Given this list of marker genes SLCO1C1, SLC35C2, SLC2A4, SLC38A1, SLC37A2, SLC6A4, SLC35D2, SLC22A6, SLC10A5, SLC25A1, SLC8A2, SLC6A9, SLC34A2, SLC26A11, SLC25A23, SLC35C1, SLC39A4, SLC17A9, SLC29A1, SLC39A8, SLC10A2, SLC5A10, SLC37A3, SLC25A6, SLC47A2 (solute carrier family 47 member 2), SLC30A8, SLC9A5 (solute carrier family 9 member A5), SLC6A3, MCU, SLC17A8, SLC25A26, SLC18A3, SLC11A2, SLCO4C1, SLC35E2A, SLC22A11, SLC36A2 (NCBI Gene Id 153201), SLC15A5, SLC6A13, SLC37A4, SLC1A3, SLC12A1, SLC30A1, SLC44A4 (solute carrier family 44 member 4), SLC35E1, SLC10A7, SLC16A5, SLC46A2, SLCO4A1, SLC17A1, SLC28A3, MFSD2B, SLC30A10, SLC22A7, SLC26A5, ANKH, ADAMTS8, SLCO1B3, SLC10A4, SLC9A2, SLC6A14, SLC5A6, SLC44A2, SLC23A2, SLC25A12, SLCO1B3-SLCO1B7, SLC2A13, SLC26A10P, CDH17, GHITM, SLC15A4, SLC6A7, SLC35A2, MFSD12, CLCN4 (NCBI Gene Id 4412), SLC35E3, SLC6A18, SLC26A7, SLC7A13, SLC11A1, SLC39A10, SLC36A1, SLC6A17, CLCN7, SLC44A5, SLC15A3 (solute carrier family 15 member 3), SLC6A11 (solute carrier family 6 member 11), SLC12A9, SLC26A3, SLC4A3 (NCBI Gene Id 7858), SLC26A9, SLC38A5, SLCO5A1, SLC35A3, SLC25A4 (NCBI Gene Id 7872), MFSD1, SLCO1A2, SLC16A12, SLC9A9, SLC24A4, SLC16A1, SLC16A4, SLC46A3, SLC22A1, SLC35A5, SLC10A3, SLC10A6, SLCO6A1, SLC13A2, SLC12A5, SLC9A6, SLC25A16, SLC10A1, SLC45A3, SLC44A1, SLC8A1, SLC17A2, SLC6A20, SLC25A25, SLC38A7, SLC16A9, SLC35E4, SLC9A1, SLC30A2, TMEM165, SLC47A1, SLC12A2, SLC24A2, SLC25A31, SLC17A4, SLC9A4, SLC39A14, SLC25A21 (NCBI Gene Id 89874), SLC2A9, SLC30A9, SLC25A11, SLC9C1, SLC5A12, SLC7A9, SLC36A4, SLC25A13, SLC4A1, SLC38A4, SLC5A2, SLC25A18, SLC5A11, SLCO1B1, SLC5A4, SLC16A7, SLC46A1, SLC39A6, SLC12A8, SLC16A2, SLC16A13, SLC1A2, SLC45A4, SLC30A4 (solute carrier family 30 member 4), SLC25A14, SLC8A3, SLC20A2, SLC26A4, SLC24A5, CLCN3, SLCO2B1, SLC28A1, SLC22A18, SLC38A2, SLC20A1, SLC34A3, SLC9B1P1, SLC18B1, SLC13A1, SLC17A5, SLC22A4 (solute carrier family 22 member 4), SLC18A2, SLC7A5, SLC6A16 (solute carrier family 6 member 16), SLC28A2, SLC23A1, SLC6A8, CLCN6, SLC39A5, SLC6A6, UCP2, SLC1A6, SLC6A15, SLC25A10, SLC24A1, SLC1A1, SLC24A3 (NCBI Gene Id 96617), SLC22A9, SLC30A3, SLC4A5, SLC1A5, SLC9A7, SLC26A6, SLC35E2B, SLC17A3, SLC15A1, SLC22A5, SLC30A5, XPR1, SLC41A3, SLC5A1, SLC26A8, SLC45A1, SLC13A4 (NCBI Gene Id 26266), SLC4A10 (NCBI Gene Id 57282), SLC39A12, SLC5A9, SLC35B2, SLC18A1, SLC35A1, SLC9B1, SLC16A11 (NCBI Gene Id 162515), SLC5A3, SLC12A7, SLC16A10, SLC35B1, SLC4A8, SLC5A5, CHP1, SLC25A30, SLC35D3, SLC25A15, MFSD4B, SLC12A4, SLC37A1, MFSD2A, SLC25A2, SLC9A8, SLC1A4, SLC4A7, SLC25A17, SLC19A1, SLC13A5, SLC4A2, SLC6A12, SLC45A2, SLC9A3, SLCO3A1, SLC12A3, SLC25A5, SLC4A4, SLC6A19, SLC30A6, SLC9B2, SLC22A8, SLC6A1, SLC25A24, SLC16A3, SLC6A5 (NCBI Gene Id 9152), SLC32A1, SLC2A10, SLC13A3, SLC7A6, SLC17A6, SLC41A1, SLC35B3, SLC25A20, SLC8B1, SLCO1B7, SLC15A2, LETM1, SLC17A7, SLC4A9, SLC36A3, SLC5A7, SLC38A3, SLC16A14, SLC1A7, SLC16A8 (solute carrier family 16 member 8), SLC26A2, CTNS, SLC4A11, SLC7A8, SLC25A19, TMCO3, SLC34A1 (solute carrier family 34 member 1), SLC25A3, SLCO2A1, SLC35D1 (solute carrier family 35 member D1), SLC5A8, SLC6A2, SLC25A22, SLC7A11, SLC9C2, SLC12A6, SLC26A1, CLCN5, TMEM241 (transmembrane protein 241), here is a description of the gene set: Human Gene Set: GOMF_SECONDARY_ACTIVE_TRANSMEMBRANE_TRANSPORTER_ACTIVITY Enables the transfer of a solute from one side of a membrane to the other, up its concentration gradient. The transporter binds the solute and undergoes a series of conformational changes. Transport works equally well in either direction and is driven by a chemiosmotic source of energy, not direct ATP coupling. Secondary active transporters include symporters and antiporters. studied in species Homo sapiens